Given this list of marker genes DENND4A, HNRNPH2, PHF21A, STK19, RABGGTA, SUN2 (NCBI Gene Id 25777), CTNNB1, FRG1, PRKRA, TMSB10 (NCBI Gene Id 9168), LASP1, RASSF7, TUBGCP2, PARN, JAK1, NELFB, PRKAG1, ARHGEF1, ATP6V1F, ZBED1, CAPZA1, RAB1A, ZNHIT3, PPP2CA, ATP6V0B, PRKCSH, TP53BP1, SMC5 (structural maintenance of chromosomes 5), KLC1, MCM3AP, UBN1, CHUK, CAPZA2, SPRN, B4GALT3, CNOT2, DNAJC13, SFSWAP, PLIN3, NT5C2, DCTN3, SMAD2, CAPZB, RTCB, RPN2, TAF9, CSNK1D, BAG1, BLTP1, EAPP, NUBP1, ERCC1, DDB1, DNAJC7, PGK1, CALM2, HNRNPK, DNAJC8, TERF2IP, TPR, NAP1L4, NSL1, SRRT, ANXA11, UBC, RABAC1, MKRN1, H3-3A, KRAS, SARAF, ATG9A (NCBI Gene Id 79065), TBCC, SERINC1, SDR39U1 (short chain dehydrogenase/reductase family 39U member 1), SH2B1, SEC61B, NUDT3, MORC3, CYB5R3, SUMO2, RBM3, CASC3, MYH9, PPP2R5A, IK, YWHAH, MAN2C1, POLR2A, DEDD, MTX1, ARL2BP, BRD3, RPLP2 (ribosomal protein lateral stalk subunit P2), CUL4B, OXA1L, BRD8, ILF2, C1D, TBCB, VPS26C, ZC3H15, ESS2, TIAL1, BECN1, TMEM59, here is a description of the gene set: studied in species Homo sapiens Human Gene Set: MORF_BECN1 Neighborhood of BECN1 Neighborhood of BECN1 beclin 1 (coiled-coil, myosin-like BCL2 interacting protein) in the MORF expression compendium